The following is a description of a gene set: Kaposi's sarcoma (KS) is caused by Kaposi's sarcoma-associated herpesvirus (KSHV) and consists of proliferating spindle cells, which are related to lymphatic endothelial cells (LEC). Angiopoietin-2 (Ang2) is a secreted proangiogenic and lymphangiogenic molecule. Here, we show the expression of Ang2 protein in KS and confirm that KSHV infection up-regulates Ang2 in LEC. We show that a paracrine mechanism contributes to this up-regulation. A lentiviral library of individual KSHV-encoding genes, comprising the majority of known latent genes and a selection of lytic viral genes, was constructed to investigate the underlying mechanism of this up-regulation. Two lytic genes, viral interleukin-6 (vIL6) and viral G-protein-coupled receptor (vGPCR), up-regulated Ang2 expression in LEC. Both vIL6 and vGPCR are expressed in KSHV-infected LEC and caused up-regulation of Ang2 in a paracrine manner. KSHV, vIL6, and vGPCR up-regulated Ang2 through the mitogen-activated protein kinase (MAPK) pathway. Gene expression microarray analysis identified several other angiogenic molecules affected by KSHV, including the vascular endothelial growth factor (VEGF)/VEGF receptor (VEGFR) axis, which is also affected by vIL6 and vGPCR in LEC, and matrix metalloproteinases, which could act in concert with Ang2 to contribute to KS development. These findings support the paracrine and autocrine roles of the lytic KSHV-encoded proteins, vIL6 and vGPCR, in KS pathogenesis and identify Ang2 as a potential therapeutic target for this neoplasm. Angiogenic markers up-regulated in lymph endothelial cells upon infection with KSHV (Kaposi's sarcoma herpes virus). from publication Vart RJ, Nikitenko LL, Lagos D, Trotter MW, Cannon M, Bourboulia D, Gratrix F, Takeuchi Y, Boshoff C (PMID 17483315) Human Gene Set: VART_KSHV_INFECTION_ANGIOGENIC_MARKERS_UP studied in species Homo sapiens, and this is the list of marker genes: FGF1, MMP19, CXCR1, NRP2, F3, ANGPT2, SERPINC1, WNT10B, CCL5, TNMD, IGF1, TIMP1, EPHB1, WNT2B, CABLES2, FGFR2, PGF, CXCL6, EPHA3, CCL11, CCR5 (C-C motif chemokine receptor 5), IFNB1, PLXDC1, SPHK1, CCN1, GRB7, TIMP3, WNT5B (NCBI Gene Id 84728), DLL4, FGFR3, CXCL5, NOTCH4, PDGFD, CALR, STAB1, DLL1, HPSE, CXCL9, HEY1, CXCL3, STAB2, COL18A1, JAG1, EPHA8, ANGPTL6, CALCRL, ANGPTL2, ADM, NOTCH2, VEGFD, IL12A (interleukin 12A), AGGF1, S1PR1, NOS3, F2R, FRS2, GRB2, ANGPTL1, TNF, COL4A3, HGF, EPHB3, TEK, HMOX1, SPP1, PECAM1, FRZB, IL6-AS1, VEGFC, PDGFA, EFNA1, ANGPT4, PTGS2 (NCBI Gene Id 5743), EFNA2, TGFB3, ROBO4, TNNI3, IL6ST, PLAU, EPHA6, TIE1, WNT10A, EFNB2, PF4, NAA15, TNNT1, TGFB1, MMP9, PROM1, EPHA7, FZD4, KRT1, BTG1, ITGB3, LPA (NCBI Gene Id 654241), JAG2, HIF1A, SPARC, PTEN, WNT2, EFNA3, FZD9, FLT4, MMP1, OSMR, TNFSF13, SFRP4, PTN, ERBB2, SERPINF1, TIMP2, CAST, COL4A2, FZD6, EGFL7, TNFAIP2, PRL, DLL3, EFNB1, IL1B, WNT1, WNT5A, FZD7, CXCL2, LINC01752, SYN1, CXCL11, TGFBR1 (transforming growth factor beta receptor 1), CXCL10, IL18, PTGS1, HEG1, EPHA1, ANGPT1, SFRP2, ARL5C, VEGFA, KDR, CXCL12, PTCHD1-AS, NRP1, PDGFB, PLAUR, SH2D2A, PLAT, PDGFRA, TMPRSS6, ENG, EPHA10, CXCR4, FLT1, ITGAV, FGFR1, EPHA4, IL10, DLK1, IL6, THBS2, ATG9B, RAMP3, COL15A1, NPR1, ERAP1, IFNA1